Given this list of marker genes AAMP, GNB4, GNGT2, GNG5 (G protein subunit gamma 5), GNGT1, GNA15 (NCBI Gene Id 2769), GNG3, GNB1, GNB3, GNA13, GNG12, GNG7, GNB2, GNA11, GNG2, GNG11, GNB5, GNG4, GNAQ, GNG13, TBXA2R, GNG10, GNA14, GNG8, here is a description of the gene set: Reactome Pathway: Thromboxane signalling through TP receptor Thromboxane (TXA2) binds to the thromboxane receptor (TP). There are 2 splice variant forms of TP, differing in their cytoplasmic carboxyl terminal tails. TP beta was first identified in endothelial cells. TP alpha was identified in platelets and placenta. The major signalling route for TP is Gq-mediated stimulation of PLC and consequent increase in cellular calcium. TP also couples to G13, leading to stimulation of Rho and Rac. species: Homo sapiens part of: Signal amplification